The following is a description of a gene set: Human Gene Set: KEGG_MEDICUS_REFERENCE_EGF_EGFR_ACTIN_SIGNALING_PATHWAY Pathway Definition from KEGG: EGF -> EGFR -> SRC -> CTTN -> NCK -> (WASL+WIPF) -> ARP2/3 -> (ACTB,ACTG1) EGF-EGFR-Actin signaling pathway. Pathway ID: N01078. Pathway type: Reference. Pathway class: nt06135 Cytoskeletal regulation (viruses and bacteria). species: Homo sapiens, and this is the list of marker genes: ARPC3 (actin related protein 2/3 complex subunit 3), ARPC5, NCK1, ARPC4, ACTR3, NCK2, WASL, WIPF1, ARPC2, SRC, ACTR2, WIPF2, EGFR, ARPC5L, EGF, WIPF3, ACTG1, CTTN, ARPC1A, ARPC1B, ACTB